Given this list of marker genes AP2B1, TAMALIN, RNF220, SCRIB, SUSD4, RALA, VAC14, NRG1, AP2M1, DRD4, EFNB2, SYT17, USP46, HIP1, ITGB3, USP6, CALY, AP2A2, RABEP1 (NCBI Gene Id 9135), PPP3R1, MDM2, ARC, CBLB, HPCA, NUMB, AP2S1, LPAR1, GSG1L, EPS15, OPHN1, NCDN, ATAD1, AP2A1, AP3M1, here is a description of the gene set: Human Gene Set: GOBP_NEUROTRANSMITTER_RECEPTOR_INTERNALIZATION A receptor-mediated endocytosis process that results in the internalization of a neurotransmitter receptor. studied in species Homo sapiens